The following is a description of a gene set: Human Gene Set: GSE41867_DAY6_VS_DAY8_LCMV_ARMSTRONG_EFFECTOR_CD8_TCELL_UP from publication Doering TA, Crawford A, Angelosanto JM, Paley MA, Ziegler CG, Wherry EJ (PMID 23159438) During acute viral infections, naïve CD8+ T cells differentiate into effector CD8+ T cells and, after viral control, into memory CD8+ T cells. Memory CD8+ T cells are highly functional, proliferate rapidly upon reinfection and persist long-term without antigen. In contrast, during chronic infections, CD8+ T cells become “exhausted” and have poor effector function, express multiple inhibitory receptors, possess low proliferative capacity, and cannot persist without antigen. To compare the development of functional memory T cells with poorly functional exhausted T cells, we generated longitudinal transcriptional profiles for each. Genes up-regulated in CD8 T effector cells, acute infection with LCMV-Armstrong: day 6 versus day 8. species: Homo sapiens, and this is the list of marker genes: NUBP1, MBD2, CAT, FKBP11, SPAG9, DYNLT3, MFSD10, CHRNB1, PROX1, CALU, BASP1, HROB, PON3, IRGQ, TATDN1, SEL1L, MAGEE1, RIPK3, LEF1, FAM117A, SSR3, NDFIP1, CRELD2, ARID3A, CCS, TNFRSF17, SLC66A2, LARS2, TMEM39A, NDUFA1, ACYP1, SEC63, ADK, ROPN1L (NCBI Gene Id 83853), LPIN1, UCHL3, PBX3 (PBX homeobox 3), CRYBG3, CCDC120, FANCL, PSD3, GAS2L3, DNAJB11, MYL4, KTN1, SSR2, PMM1, MANEA, ERLEC1 (endoplasmic reticulum lectin 1), TBC1D4 (NCBI Gene Id 9882), SLC44A1, NELFE (NCBI Gene Id 7936), ECHDC3, ZNF521, ADH5, GRSF1, RNASEH2A, ZNF277, ANTXR2, VSIR, KCTD14 (NCBI Gene Id 65987), UNG, TCEAL9, BZW2, SMPD1, PUM1, CENPL, GMPPA, MRPS14, VEGFA, CDKN3, PIGY, KHDRBS1, ATXN1, FNDC3B, MCTP2, SDC1, DNPEP, PARP1, RPL32, SAV1 (NCBI Gene Id 60485), MSRB3, TAF5L, ANKRD55 (NCBI Gene Id 79722), MAPRE2, GALK1, SLPI, LRRC8C, GALNT2 (polypeptide N-acetylgalactosaminyltransferase 2), AFG2B, MAN1B1, ABCB4, MAMDC2, TIMM17B, USP2, CMAS, SRP9, AVPI1, GALC, RAP1A, FAM199X, RFTN1, GNE, ZNF180, CKS1B, TMEM30A, SLC30A5, MUTYH, KIF2A, ASB5, MRPL41, EPRS1, KRT10, ANKLE2, DERL1, SLC35B1, TOR2A, TMEM97, RGS10, CD48, PLA1A, UBA5, EYA1, CPEB3, B3GNT9, POGZ, PDIA4 (NCBI Gene Id 9601), RIOK1, SFN, MAP3K12, GYG1, FAS, CNST, H2AX, TRAF6, SOWAHC, CLCN3, PIMREG, GUSB, BID, AMIGO2, GPM6A, RSAD1, MZB1, IL6ST, PPP1CC, HRH2, BEX3, PIM2, RAPGEF4, SLC2A3, BPGM, ZYG11B, SPATA24, PLXNB3, TACSTD2, PRELID1, VKORC1L1, DENND2D, TAF15, IBA57, MYDGF, MYO7B, ELL2, CKAP4, MTM1, AQP3, WFS1, RAB33B, ALCAM, RPL28, GINM1, STT3A, PAFAH1B3, YWHAQ, CTH, C12orf56, COPS4, CEP68, PLPP2, SMAP1, DERL3, HACD1, CD93, PRDX4, UTP14A, APOA2, IPMK, LCA5, MYBL1, BIRC6, PYCR1, TMEM203, MUC1, GCAT, CTDP1, PPARA, SLC2A6, ZNF330, DNAJC3